Given this list of marker genes KANSL1, MCFD2, SDHAF2, PDE11A, SMARCAL1, DOCK8, TGFBR3, BUD23, ASS1, GRN, TNXB, LMNA, LIMK1, PCSK9, JAG1, TP53, SMO, CD109, SMARCE1, NF1, MARS2, MT-TL1, PSEN1, CCM2, TERT, RNU7-1, SDHB, CLIP2, WAS, TTR, NFIA, LOX, HTRA1, PNP, NF2, FGG, MT-CO1, RFC2, GNAQ, GUCY1A1, MT-ND1, RET, SNORD118, HBB, KRAS (NCBI Gene Id 3845), TMEM270, TMEM127, SAMHD1, TREM2, CITED2, GLA, ANO1, TMEM237, BAZ1B, SDHA, LDLRAP1, MSX2, USP8, IFIH1, KMT5B, BAP1 (NCBI Gene Id 8314), PRKCSH, COLGALT1, ALPL, MYH6, ABCG5, AGXT, EPOR, SUFU, BRCC3, NDE1, ACTC1, USP18, H3-3A, NGLY1, RNF213, STX1A (syntaxin 1A), ITGA2B, ZMPSTE24, XYLT1, MLXIPL, ERCC8, AMACR, TNNT2, IFT140, VCP, TGFB2 (transforming growth factor beta 2), PRKCH, SDHD, NDUFA8, APOB, CALR, SPTBN1, DPM3, WIPF1, COL1A1, METTL27, DCX, HES7, SCN5A, DHPS, NAGS, PDCD10, RBM10, SMAD2, ENG, EIF4H, SON, LIG3, MT-TV, FHOD3, ABCG8 (ATP binding cassette subfamily G member 8), GP1BA, NKX2-5, CYP26C1, ASXL2, SIAH1, STT3A, B3GALT6, MYBPC3, RPL10, SLC20A2, DYRK1B, PIGA, MYH11, CPS1, MT-ND4, CD46, SLC2A10, GTF2IRD2, CYP11B1, CUL7, TRAF7, PRKAR1A, CST3, PDGFRB, RNASEH2B, VHL, ADAR (NCBI Gene Id 3427), TGFBR1, PKD2, CCDC8, HADHB, GANAB, CFI, GNB2, BRAF, PRKG1, DPAGT1, GATA4, CNTNAP2, KCNJ5, ALG2, LDLR, VPS37D, PROS1, SERPINE1, GAA, NOS3, IL6, USP48, KRIT1, MAPT, ALX4, ZAP70 (NCBI Gene Id 7535), ALDH18A1, ERCC6, CLCN3, ANTXR1, GNAI3, CYP11B2, RNU4-2, MMUT, TET2, EDN1, SLC25A11, CFH, SMARCB1, MAT2A, FBN1, GTF2IRD1, STIM1, OTC, ALG5, ADA2, APOA1 (NCBI Gene Id 335), GTF2I, MT-TH, MDH2, FOXE3, DLST, ACTG1, DNMT3A, MTHFR, AIRE, PTEN, MT-ND5, PCCA, RIN2, ALOX5AP, LMOD2, LMBRD1, ATRX, ELN, PIK3C2A, COL4A1, PRNP, TBX20, MPL, THSD1, MYH7, MT-CO2, GDF2, DNAJB11, TNNI3, RNASEH2A, CBS, CCND1, XYLT2, TMEM106B, RNASEH2C, ACTB, COL5A1, MT-ND6, BICC1, DNAJC30, F13A1, IKBKG, GATA6 (GATA binding protein 6), MT-TS2, MYPN, OBSL1, ABCC6, DIAPH1, PIK3CA, COL5A2, THSD4, ACTA2, THPO, CDH23, ODC1, MECP2 (NCBI Gene Id 8274), MYD88, BGN, PAFAH1B1, MFAP5, NCF1, STAT1 (NCBI Gene Id 6772), PLXNA1, BICD2, SAMD9, ADAMTS13, CHMP2B, COL3A1, CPT2, RFT1, LRP5, FARSB, MCCC2, EXT2, PDGFB, FCGR2C, JAK2, MAX, EPHB4, ACVRL1, NPPA, MT-TC, ENPP1, LMAN1, DNM2, MT-TK, TPP2, ALG9, MT-TQ, GCDH, KIF1B, ACTA1, CACNA1D, SH2B3, ZSWIM6, WRN, ATP2B1, NR3C1, NOTCH3, F2, PMM2, SERPINF2, SMAD3, PLCB4, ESAM, SEC63, PCNT, GALE, SDHC, COL4A2, LSM11, CLCN2, SNAP29, MT-TF, TBL2, F10, GP1BB, TGFB3, MMACHC, F8, TANGO2, MLX, GGCX, MT-TW, EPAS1, ZFX, F7, APP, CMPK2, LRPPRC, PROC, RASA1, HLA-B, PLIN1, IPO8, PLOD3 (procollagen-lysine,2-oxoglutarate 5-dioxygenase 3), ITGA2, PKD1, PCCB, SLC19A2, TLL1, PET100 (PET100 cytochrome c oxidase chaperone), WFS1, F13B, POLR3F, SMAD4, KIF20A, AKT1, SIN3A, TONSL, GBA1, MCCC1, FH, FN1, ITGB3, FGB, RNF168, HELLPAR, STAT2, FGA, MYLK, MT-CYB, GATA2, TRPV6, GLUL, FLNC, NAGA, HEY2, SPARC, GYS1, FKBP6, IL12B, H4C9, EFEMP2, FLNA, ANGPTL6, HSD11B2, ACAD9, TREX1, F5, IVD, ATP7A, TGFBR2, MT-CO3, here is a description of the gene set: Abnormal cerebral vascular morphology An anomaly of the cerebral blood vessels. species: Homo sapiens Human Gene Set: HP_ABNORMAL_CEREBRAL_VASCULAR_MORPHOLOGY